The following is a description of a gene set: Genes in hepatocellular carcinoma (HCC) subclass G2, defined by unsupervised clustering. Human Gene Set: BOYAULT_LIVER_CANCER_SUBCLASS_G2 Hepatocellular carcinomas (HCCs) are a heterogeneous group of tumors that differ in risk factors and genetic alterations. We further investigated transcriptome-genotype-phenotype correlations in HCC. Global transcriptome analyses were performed on 57 HCCs and 3 hepatocellular adenomas and validated by quantitative RT-PCR using 63 additional HCCs. We determined loss of heterozygosity, gene mutations, promoter methylation of CDH1 and CDKN2A, and HBV DNA copy number for each tumor. Unsupervised transcriptome analysis identified 6 robust subgroups of HCC (G1-G6) associated with clinical and genetic characteristics. G1 tumors were associated with low copy number of HBV and overexpression of genes expressed in fetal liver and controlled by parental imprinting. G2 included HCCs infected with a high copy number of HBV and mutations in PIK3CA and TP53. In these first groups, we detected specific activation of the AKT pathway. G3 tumors were typified by mutation of TP53 and overexpression of genes controlling the cell cycle. G4 was a heterogeneous subgroup of tumors including TCF1-mutated hepatocellular adenomas and carcinomas. G5 and G6 were strongly related to beta-catenin mutations that lead to Wnt pathway activation; in particular, G6 tumors were characterized by satellite nodules, higher activation of the Wnt pathway, and E-cadherin underexpression. CONCLUSION: These results have furthered our understanding of the genetic diversity of human HCC and have provided specific identifiers for classifying tumors. In addition, our classification has potential therapeutic implications because 50% of the tumors were related to WNT or AKT pathway activation, which potentially could be targeted by specific inhibiting therapies. studied in species Homo sapiens from publication Boyault S, Rickman DS, de Reyniès A, Balabaud C, Rebouissou S, Jeannot E, Hérault A, Saric J, Belghiti J, Franco D, Bioulac-Sage P, Laurent-Puig P, Zucman-Rossi J (PMID 17187432), and this is the list of marker genes: MLLT11, HIP1, RPN2, PAN2, CNPY2, SATB2, CD58, EPHA1, AMIGO2, ALDOC, SLC2A6, NAV3, MCTP1 (NCBI Gene Id 79772), FHOD3, INTS7, ITGA5, KIF14, ENPP2, KLHL7, MOSPD1, SDF2L1, MEIS2 (NCBI Gene Id 56908), MOAP1, DEGS1, INHBB, RRAS2, ARHGEF40, SAP130